The following is a description of a gene set: We demonstrate that the G protein Gi3 is the cellular target of the adenosine A3 receptor (A3R). By using a cell permeable peptide comprising the C-terminal end of Gαi3 fused to an importation sequence (ALL1) as a selective inhibitor of Gi3 signaling, we show that by coupling to Gi3, the A3R stimulates multiple signaling pathways in human mast cells, leading to upregulation of cytokines, chemokines and growth factors.Following contact with activated T cell membranes, endogenous adenosine binds to and activates the A3R, resulting in Gi3-mediated signaling. Specifically, the majority of ERK1/2 signaling initiated by contact with activated T cell membranes, is mediated by Gi3, giving rise to ALL1-inhibitable cellular responses. These results unveil the physiological GPCR that couples to Gi3 and establish the important role played by this G-protein in inflammatory conditions that involve adenosine-activated mast cells. We used microarrays to detail the effect of ALL1 on gene expression of HMC-1 cells activated directly by the A3 receptor, or by contact with activated T cell membranes. from publication Baram D, Dekel O, Mekori YA, Sagi-Eisenberg R (PMID 20190146) species: Homo sapiens Genes up-regulated in HMC-1 (mast leukemia) cells: Cl-IB-MECA versus T cell membranes. Human Gene Set: GSE19888_ADENOSINE_A3R_ACT_VS_TCELL_MEMBRANES_ACT_IN_MAST_CELL_UP, and this is the list of marker genes: PLCB1, SMARCA1, FUT11, PTPN18, RTN4RL2, EDEM1, ARHGAP30, GNG2, ADAMTS2, MS4A6A, ECSCR, CALHM6, CTBS, PNLIP, RAB43, CARD11, AP2A2, ATP8B4, GBP7, GMPPA, PPP1R18, SERPING1 (serpin family G member 1), VSIR, SLC16A12, RNASEH1, EPHA3, COL5A2, SLC13A5, SASH3, EIF1B, GNB5 (NCBI Gene Id 82962), GPM6B, TIMD4, NID1, TIFAB, EFEMP2, TCEAL1, PPIC, FERMT3, FADS1, SDHAF2, LAMA4, COL3A1, SPACA9, GPX3, CTSZ, DYNLT1, CRIP1, CPXM1, CPA6, HFE, DLGAP1-AS1, EIF4E3, APEH, CDC42SE2, SLC11A1, ITGA1, BLVRA, FXN, SLC25A45, GNAI2, MYO7A, ERG, UBD, P2RY6, SDHD, TMEM160, ITGAM, ADA, IFI27L2, MGAT1 (NCBI Gene Id 4245), IRF8, LMO2, RNF144A, MS4A8, HMBOX1, IL6ST, RYK, VWA5A, CASP1, SDC3, COLCA1, PLIN2, RGL1, C4B, FANCA, CD276, IFNAR2, LAIR1, SLC12A7, CTSE, NFAM1, FEZ2, SNED1, FAAP24, MYO1F, TBXA2R, CTSC, SPON1, PKHD1L1, BACE1, FBXO4, LSP1, HK3, PRTG (NCBI Gene Id 650816), EPS8 (EGFR pathway substrate 8, signaling adaptor), DRAM1, PID1, WASHC5, NCKAP1L, TIMP1, MRPL23, CTSS, TENT2, SYDE1, LAMP2, SMIM20, ERLEC1 (NCBI Gene Id 27248), NCF4, SQOR, GNAS, LUM, BAK1, AGTRAP, AIF1, CXCL9, SMPDL3B, FKBP1B, VPS35L, SNX10 (sorting nexin 10), SELPLG, RAB42, LCK (NCBI Gene Id 95387), CORO7, BLVRB, ARPC3, TNFRSF13B, B2M, MRC2, GPX7, APOL6, NRP2 (NCBI Gene Id 8828), GGA2, DCN, TRPV2, F2RL3, APOBR, OAF, CCDC54, IRF1, TCEAL9, GALNS, C1QB, OSR2, HIP1 (huntingtin interacting protein 1), ERGIC3, RARRES2, BMP8B, NRSN2, CHID1, KISS1R, LY9, CLTA, ADGRE5 (adhesion G protein-coupled receptor E5), SNX24, HPSE, GBP2, GLT8D1, CASP12, TLN1 (NCBI Gene Id 7094), ARHGDIB, UVRAG, PCOLCE, B3GALNT1, GPSM3, SERPINA3, RCN3, LY96, SLC38A10, CAPNS1, ADAM12, XRN2, IDNK, PSMB9, TGFB1, C1R, MPI, HOXD4, TAFA2, TIFA, SSC5D (scavenger receptor cysteine rich family member with 5 domains), C1QC, HCST, TYROBP, STAT1, PHC2, HLA-DMA, COL6A1, DENND2A, MYO1G